Given this list of marker genes RPP14, RNASEH1, MRPL44, AGO2 (NCBI Gene Id 286109), CWF19L1, POP5, APEX1, NUDT16L1, DBR1, NUDT16, RNASEH2A, RPP21, RPP38, POP7 (NCBI Gene Id 82671), FEN1, RPP25, RPP30, POP4, RPP40, DROSHA, EXO1, DICER1, RPPH1, ELAC2, AGO3, NYNRIN, ELAC1, POP1, NUDT12, PRORP, ENDOV, PLD6, here is a description of the gene set: Catalysis of the hydrolysis of ester linkages within ribonucleic acids by creating internal breaks to yield 5'-phosphomonoesters. Human Gene Set: GOMF_RNA_ENDONUCLEASE_ACTIVITY_PRODUCING_5_PHOSPHOMONOESTERS species: Homo sapiens